Given this list of marker genes VAPA, CRY2, CEBPB, SUMO3, G0S2, PER1, GSTM3, PSMA4, CLOCK, QKI, SF3A3, TUBB3 (NCBI Gene Id 94749), PER2, AZIN1, PIGF, PPP2CB, BMAL1, GFRA1, PURA, NCKAP1, CRY1, KLF9, CBX3, MYF6, BTG1, RBPMS, CLDN5, DNAJA1, UCP3, H2BC15, TOB1, HLA-DMA, SUMO1, GSTP1, HSPA8, IDI1, ETV6, TAB2, DAZAP2, ZFR, ERC2, NR1D2, EIF4G2 (NCBI Gene Id 1982), STBD1, UGP2, PPP1R3C, NCOA4, HERPUD1, here is a description of the gene set: Human Gene Set: WP_EXERCISEINDUCED_CIRCADIAN_REGULATION Exercise-induced circadian regulation species: Homo sapiens